Given this list of marker genes ST14, CYP2S1, PKIB, SPINT1, P2RY14, FILIP1L, LPXN, IL1R2, CD1C, CD69, FBLN2, ADAM8, COL9A2, MOB3B, ADAM28, IL18BP, MAP4K1, GPAT3, MSLN, SLC38A1, KCNMB1 (NCBI Gene Id 3779), IL18, NR4A3, TMEM8B, VOPP1, NAPSA, GEM, PTGDR2, SNAI3, CD1E, SLAMF8, BCL7A, TVP23A, HLA-DOA, S100B, FCGR2B, KIF17, HLA-DQB2, CCDC86, NDRG2, FLT3, TMEM273, IRF4, LGALS2, TCTN3, TLR10, FCER1A, PPP1R14A, ALCAM, NCKAP5, TMEM156, ARL4C, here is a description of the gene set: from publication He P, Lim K, Sun D, Pett JP, Jeng Q, Polanski K, Dong Z, Bolt L, Richardson L, Mamanova L, Dabrowska M, Wilbrey-Clark A, Madissoon E, Tuong ZK, Dann E, Suo C, Goh I, Yoshida M, Nikolić MZ, Janes SM, He X, Barker RA, Teichmann SA, Marioni JC, Meyer KB, Rawlins EL (PMID 36493756) Human Gene Set: HE_LIM_SUN_FETAL_LUNG_C2_DC2_CELL DC2 species: Homo sapiens